The following is a description of a gene set: Mouse Gene Set: GOBP_RESPONSE_TO_GROWTH_HORMONE Any process that results in a change in state or activity of a cell or an organism (in terms of movement, secretion, enzyme production, gene expression, etc.) as a result of a growth hormone stimulus. Growth hormone is a peptide hormone that binds to the growth hormone receptor and stimulates growth. studied in species Mus musculus, and this is the list of marker genes: F7, Jak3, Ghr, Stat5b, Socs2, Abcc2, A1bg, Phex (NCBI Gene Id 237149), Pxn, Star, Hmgcs2, Jak1, Mbd5, Tyk2, Stat5a, Shoc2, Ptk2, Irf1, Leprotl1, Gdf15, Stat3, Jak2, Cps1, Stat6, Ass1, Ghsr, Gh, Akt1, Pik3r1, Adrm1, Igfbp5, Leprot, Pnpt1, Cacybp